Given this list of marker genes RASGRF2, AXIN2, MSRB2, SPPL2A, KIAA0040, PELI1, SORL1 (sortilin related receptor 1), NSG2, ACTN1, CRBN, ESM1, DNAH8, MXRA8, VRK3, CHD2, SLC16A5, NMB, TBC1D1, ZBTB44 (zinc finger and BTB domain containing 44), ZFP36 (NCBI Gene Id 7538), MSRA, ZBTB7B (zinc finger and BTB domain containing 7B), PDE5A, LHFPL3, NT5DC1, LRRC75B, HAL (histidine ammonia-lyase), SERPINI1, ATP10D, TMEM229B, AKNA, SGK3, CERS6, MAP3K3, PRF1, HCST, CD8B, IDUA, EVI2A, CD200R1L, MOB1A, RNF32, ARMC3, ATP8B4, DENND1C, IFIT1B, PGAP1, C5orf34, DMTF1, PAQR7, GGT1, MYLIP, MAP2K6, HLA-DQA1, KIF21B, CYRIA, XKRX, PNPLA7, CNGA1, NQO2, LYPD6B, TPCN1, CCL5, LGALS8, SMC6, DAXX, PITPNC1, CYTH1, IFIT1, ARHGAP9, MEX3B, RAPGEF4, PTPRE, MAGEF1, NBEAL1, NUDT16, TDRP (NCBI Gene Id 157695), MATK, ARHGAP4, KCTD12, TSPAN13, SPO11, RUFY2 (RUN and FYVE domain containing 2), IL27RA, ZMYND11, RSBN1, C3orf70 (chromosome 3 open reading frame 70), MEF2D, ATF7IP, GSN, HEBP1, SCML4 (NCBI Gene Id 256380), STXBP3, PRKAB1, ZNF292, PDE2A, HMBOX1, CHST10 (NCBI Gene Id 9486), GLCCI1, HLA-DRB1, TMEM63A, CD96, CD84, CARNS1, USP32, EHD3 (EH domain containing 3), ARHGAP26, TCF20, KLHL42, KLRD1, RAP1GAP2, SLC14A1, ADGRE5, PRDM1, DSE, ACAP1, CHDH, TET1, STK4, EEIG1, CAMKMT, EPSTI1, MYCBP2, RASGRP2, PAXX (NCBI Gene Id 286257), LNPEP, L1CAM, PLEKHG2, LIPA, ZNF418, APPL2, PARP12, RASGRP1, ADGRG3, GRAMD1A, CREB1, FAM117A (NCBI Gene Id 81558), ZNF571, RIMOC1, PRR14, ASAP1, KREMEN1, ANXA1, SYNE2, ZNF354C, D2HGDH, POLR3GL, NLK, CYP2D6, BICRA, KMT2E, PGLYRP1, DUSP7, EVI2B, P2RX7, AMPD3, SMAD4, SLFN13, FICD, CTSE, PITPNM1, TMEM31, ITM2C, TBCEL, C19orf38, NIPAL3, PPM1K, ADAR, SRSF12, CCR9, DZIP1, SRPK2 (NCBI Gene Id 6733), KLHDC1, VEZF1, LPP-AS2, DNAJC6, AMPD1, ACVR1B, CD7, KBTBD2, SCG5, CYP2S1, SP4, SMPD5, RAMP3, DTX1, USP53, VIPR1, AMIGO2, BAZ2B, BLTP1, RALGAPA2, CATSPERD, BTLA, SCP2, ARHGEF10 (Rho guanine nucleotide exchange factor 10), TNFRSF1A, GABRR2, SH3PXD2A, CD1D, here is a description of the gene set: species: Homo sapiens Genes down-regulated in CD4 T cells with STAT3 knockout: TGF beta versus IL6. STAT3, an essential transcription factor with pleiotropic functions, plays critical roles in the pathogenesis of autoimmunity. Despite recent data linking STAT3 with inflammatory bowel disease, exactly how it contributes to chronic intestinal inflammation is not known. Using a T cell transfer model of colitis we found that STAT3 expression in T cells was essential for the induction of both colitis and systemic inflammation. STAT3 was critical in modulating the balance of T helper 17 (Th17) and regulatory T (Treg) cells, as well as in promoting CD4+ T cell proliferation. We used chromatin immunoprecipitation and massive parallel sequencing (ChIP-Seq) to define the genome-wide targets of STAT3 in CD4+ T cells. We found that STAT3 bound to multiple genes involved in Th17 cell differentiation, cell activation, proliferation and survival, regulating both expression and epigenetic modifications. Thus, STAT3 orchestrates multiple critical aspects of T cell function in inflammation and homeostasis. from publication Durant L, Watford WT, Ramos HL, Laurence A, Vahedi G, Wei L, Takahashi H, Sun HW, Kanno Y, Powrie F, O'Shea JJ (PMID 20493732) Human Gene Set: GSE21670_TGFB_VS_IL6_TREATED_STAT3_KO_CD4_TCELL_DN